Given this list of marker genes Flvcr2, Slc44a5, Slc44a1, Slc44a4, Slc6a8, Slc5a7, Flvcr1, Slc44a2, Slc22a2, here is a description of the gene set: Enables the transfer of choline from one side of a membrane to the other. Choline (2-hydroxyethyltrimethylammonium) is an amino alcohol that occurs widely in living organisms as a constituent of certain types of phospholipids and in the neurotransmitter acetylcholine. studied in species Mus musculus Mouse Gene Set: GOMF_CHOLINE_TRANSMEMBRANE_TRANSPORTER_ACTIVITY